Given this list of marker genes Sost, Vdac2, Ifi209 (NCBI Gene Id 98348), Svil, Nol3, Snca, Ep300, Raf1, Tmod2, Fhod3, Cldn7, Clip3 (NCBI Gene Id 76686), Clu, Ssh2, Dmtn, Gsk3b, Hspa5, Eml2, Lmod3, Rpl13a, Jam3, Syt11, Capza1b, Lcmt1, Cfl1, Nop53, Ddx3x, Myadm, Eif4ebp1, Riok3, Tlr2, Ogt, Myh9, Sox9, Pfn1, Lmod2, Ankrd27, Mtpn, Tmod4, Ssh3, Dact1, Flii, Trim11, Add3, Nlrc3 (NCBI Gene Id 268857), Bbs4, Ptger4, Tmsb15b2, Evl, Sgk1, Lamp2, Add1, Twf2, Trim31, Capzb (NCBI Gene Id 80668), Map3k7, Prkcd, Hip1r, Xaf1, Sorl1, Tubb4a, Lmo4, Tpm1, Mapre1, Ssh1, Ctnnbip1, Dkk1, Fbxl2, Jmjd6, Thra, Aida, Arhgef7, Dyrk1a, Carmil1, Igtp, Capn1, Add2, Stmn2, Isl1, Arhgef2, Mkks, Spta1, Lefty1, Tmod3, Capza2, Arfgef1, Capza1, Tmsb4x, Ifi214 (interferon activated gene 214), Trim30a, Traf3ip1, Map2, Dnajc15, Kank1, Kif14, Ifi207, Prrt2, Cyrib, Sirt2, Cdh5, Arpc2, Mndal (NCBI Gene Id 192690), Kank2, Tmc8, Capza3, Inpp5j, Pfn2, Gba1, Rdx, Ifi208, Trim9, Abhd17a (abhydrolase domain containing 17A), Hmgb1, Hdac6, Cptp, Cracd, Ifi203, Ifi213, Cryab, Hsf1, Hspa8, Zdhhc12, Akain1, Twf1, Capg, Src, Gsn, Irgm1 (NCBI Gene Id 15944, immunity-related GTPase family M member 1), Ulk1, Sptan1, Dbnl, Trem2, Prkcz, Birc2, Ifi206, Kank4 (NCBI Gene Id 242553), Svip, Carmil2, Fkbp4, Slit2, Park7, Sptbn1, Sptb, Eps8, Avil, Ifi203-ps, Lmod1, Kank3, Tbcd, Tmsb15l, Scin, Mefv, Vil1, Crbn, Vill, Cdc42, Pex5, Oprd1, Pecam1, Tmod1, Stxbp1, Stmn1, Csnk1a1, D1Pas1, Vps35, Zfp827, Tfip11, Irgm2, here is a description of the gene set: studied in species Mus musculus Any process that stops, prevents, or reduces the frequency, rate or extent of protein complex assembly. Mouse Gene Set: GOBP_NEGATIVE_REGULATION_OF_PROTEIN_CONTAINING_COMPLEX_ASSEMBLY